Given this list of marker genes Morc2a, Setdb1, Morc2b, Top2b, Inpp5k, Hmga2, Smarcb1, Aicda, Apobec3, Zfp809, Mphosph8, Tasor, Top2a, Trim28, here is a description of the gene set: A viral genome replication where the template is single-stranded RNA (ssRNA), and which proceeds via a double stranded DNA (dsDNA) intermediate molecule. Viral genomic RNA is first reverse transcribed into dsDNA, which integrates into the host chromosomal DNA, where it is transcribed by host RNA polymerase II. studied in species Mus musculus Mouse Gene Set: GOBP_SINGLE_STRANDED_VIRAL_RNA_REPLICATION_VIA_DOUBLE_STRANDED_DNA_INTERMEDIATE